The following is a description of a gene set: The binding activity of a molecule that brings together two or more molecules in a signaling pathway, permitting those molecules to function in a coordinated way. Adaptor molecules themselves do not have catalytic activity. studied in species Mus musculus Mouse Gene Set: GOMF_SIGNALING_ADAPTOR_ACTIVITY, and this is the list of marker genes: Traf4, Wwc2, Rack1 (NCBI Gene Id 14694), Wdr59, Shc1, Gnb2 (NCBI Gene Id 14693), Nlrp3, Fcrl2, Dab2ip, Nos1ap, Sh2b1, Dab1, Dusp19, Nlrp1b, Dok2, Shank3 (SH3 and multiple ankyrin repeat domains 3), Bin1, Spata2, Fadd, Sting1, Hax1, Frs2, Shank1, Gab3, Pxn, Traf3, Frs3, Caprin1, Spag9, Crkl, Gnb3, Sarm1, Ripk2, Nlrp1a (NCBI Gene Id 435266), Traf2, Nsmaf, Cdh5, Rgs14, Shb, Tradd, Sh2d1b1, Socs7, Nlrp6, Scrib, Nck2, Homer2, Socs6, Ldlrap1, Gab1, Lat, Fmr1, Akap13, Lrrk2, Sh2b3, Ddx3x, Bank1, Akap12, Ticam2 (TIR domain containing adaptor molecule 2), Gab2, Ikbkg, Aim2, Crk (v-crk avian sarcoma virus CT10 oncogene homolog), Map2k1, Stap2, Sla2, Abi3, Myd88, Lamp2, Sh2d3c, Stap1 (NCBI Gene Id 56792), Zdhhc11, Sorbs1, Ywhae, Arf6, Bcl10, Sqstm1, Grb10, Abi1, D1Pas1, Khdrbs1, Ifnar1, Sh2b2, Mapk8ip1, Gnb4, Traf5, Mapk8ip3, Cdc42se2 (CDC42 small effector 2), Ticam1, Nck1, Ripk1, Nup62 (nucleoporin 62), Grb2, Card9, Irs2, Irak2, Hcls1, Mapk8ip2, Abi2, Axin1, Wwc1, Irs1, Ksr2 (kinase suppressor of ras 2), Dok7, Mavs, Map2k2, Ptpn11, Irak1bp1, Blnk, Iqgap1, Magi2, Tirap, Sh3rf1 (SH3 domain containing ring finger 1), Stat3, Ksr1, Traf1 (TNF receptor-associated factor 1), Gnb1, Gnb5, Traf6